The following is a description of a gene set: CD8 T cells play a crucial role in immunity to infection and cancer. They are maintained in constant numbers, but upon stimulation with antigen undergo a developmental program characterized by distinct phases encompassing the expansion and then contraction of antigen-specific populations, followed by the persistence of long-lived memory cells. Although this predictable pattern of a CD8 T cell response is well established, the underlying cellular mechanisms regulating the transition to memory remain undefined. Here we show that TRAF6, an adapter protein in the TNF-receptor (TNFR) and IL-1R/TLR superfamily, regulates CD8 T cell memory development following infection by modulating fatty acid metabolism. We show that mice with a T cell-specific deletion of TRAF6 mount robust primary CD8 T cell effector responses, but have a profound defect in their ability to generate memory. This defect is CD8 T cell intrinsic and is characterized by the disappearance of antigen-specific cells in the weeks following primary immunization. Microarray analyses revealed that TRAF6-deficient CD8 T cells from early timepoints following immunization exhibit altered expression of genes that regulate fatty acid metabolism. Consistent with this, activated CD8 T cells lacking TRAF6 are unable to upregulate mitochondrial β-oxidation in response to growth factor withdrawal in vitro. Treatment with drugs that induce fatty acid oxidation enabled CD8 T cell memory generation in the absence of TRAF6. Remarkably, these treatments also increased CD8 T cell memory in wild type mice, and consequently were able to significantly improve the efficacy of an experimental anti-cancer vaccine. Human Gene Set: GSE15750_DAY6_VS_DAY10_TRAF6KO_EFF_CD8_TCELL_UP Genes up-regulated in comparison of wild type CD8 effector T cells at day 6 versus those from mice defficient for TRAF6 at day 10. studied in species Homo sapiens from publication Pearce EL, Walsh MC, Cejas PJ, Harms GM, Shen H, Wang LS, Jones RG, Choi Y (PMID 19494812), and this is the list of marker genes: NDUFS8, SMC2, ROM1, ARHGAP11A, DHFR, TTK, NUP93, CCNF, STIL, PLA2G4C, NUF2, GEN1, KIF18B, MAD2L1, KIF20B, MGST3, SKA3, PCNA, FOXM1, HMGB2, TICRR, CDC25C, MCM3, SPAG5, ANLN, CPOX, DNA2, ARHGAP19, RAD51AP1, CCDC138, CCDC43, SLC25A6, HMMR, TMEM107, CDC6, AURKA, CHEK1, HMGB3, PSRC1, TK1, INCENP, TSPAN32, CENPN, CDKN3, MAPK1, DEPDC1, GGT1, TCF19, CSRP1, CLSPN, AURKB, MIS18BP1, TOP2A, POLA1, RACGAP1, MTM1, MYBL2, BRIP1 (NCBI Gene Id 83991), RRM1, APLP2, BIRC5, NTF4, HPF1, RASSF3, PSAT1, PRR11, SFR1, GRB10, TFDP1, GNG3 (G protein subunit gamma 3), AUNIP, KIF4A, GTSE1, TPX2, MUC20, LRR1, RAD51, PMCH, TUBA1B, ZWILCH, NCAPH, ECT2, CENPA, CIP2A, CDC45, PBK, PIMREG, RPS27L, NUP205, SPC25, ORC1, MCM6, CDCA5, SPDL1, RFC5, MKI67, CDK1, TUBB4B, HROB, UBE2N, BCAT1, RBMX, E2F8, PRIM1, KNSTRN, NSL1, PASK (PAS domain containing serine/threonine kinase), ASPM, CBX5, NINJ2, PIF1, CENPP, SYNRG, CCAR1, CA5B, MRPL20, RRM2, PXMP2, CDKN1A, MTFR2, ITGA2, SKA1, CKS1B, NCAPG, CENPI, ESCO2, EXO1, KIF20A, CCNB2, CLDND1, PCYT1B, TACC3, CENPK, FAM114A1, EZR, KIF24, KNL1, ACADL, RNASEH2B, CDCA7L, PFDN4, IRAK1BP1, MND1, NCAPG2, DUT, UBE2C, SPC24, CKAP5, KIF22, SHCBP1, SRL, BUB1, CKAP2, MIS12, PRELID3B, CENPE, COX7A1, CKAP2L, PARPBP, FANCD2, KIF23, NEK2, CENPM, CDCA3, STMN1, CDCA2, EME1, ARL6, NMRAL1, MELK, CTLA4, FKBP5, PRSS16, PLK1, FAM221A, MCM10, LIG1, PLAA, UHRF1, MXD3, SEPTIN11, SEPTIN2, FEN1, BUB1B, PTGR1, TPPP3, KIF2A, E2F7, CCNA2, MT2A, DTL, CENPF, CCT2, POLE (DNA polymerase epsilon, catalytic subunit), SNAP29, SQLE, CEP55, MLF1, CENPH, MT1E